The following is a description of a gene set: species: Mus musculus Providing the environmental signal that initiates the directed movement of a motile cell or organism towards a lower concentration of that signal. Mouse Gene Set: GOMF_CHEMOREPELLENT_ACTIVITY, and this is the list of marker genes: Sema4f, Sema3e, Sema6c, Sema4g, Sema3c, Dpp4, Apoa1, Sema3d, Nrg3, Sema5b, Flrt2, Sema4d, Sema5a, Sema6d, Sema3g, Efna5, Sema4c, Epha7, Flrt3, Nrg1, Sema3f, Sema7a, Slit2, Sema4b, Sema6b, Sema3b, Sema3a, Sema4a, Sema6a